The following is a description of a gene set: In addition to its well-characterized role in estrogen-dependent transcription, estrogen (beta-estradiol, also known as E2) also plays a rapid, non-genomic role through interaction with receptors localized at the plasma membrane by virtue of dynamic palmitoylation. Estrogen receptor palmitoylation is a prerequisite for the E2-dependent activation of extra-nuclear signaling both in vitro and in animal models. Non-genomic signaling through the estrogen receptor ESR1 also depends on receptor arginine methylation by PMRT1. <br>E2-evoked extra-nuclear signaling is independent of the transcriptional activity of estrogen receptors and occurs within seconds to minutes following E2 administration to target cells. Extra-nuclear signaling consists of the activation of a plethora of signaling pathways including the RAF/MAP kinase cascade and the PI3K/AKT signaling cascade and governs processes such as apoptosis, cellular proliferation and metastasis. ESR-mediated signaling also cross-talks with receptor tyrosine kinase, NF- kappa beta and GPCR signaling pathways by modulating the post-translational modification of enzymes and other proteins and regulating second messengers. In the nervous system, E2 affects neural functions such as cognition, behaviour, stress responses and reproduction in part by inducing such rapid extra-nuclear responses, while in endothelial cells, non-genomic ESR-dependent signaling also regulates vasodilation through the eNOS pathway. <br>Extra-nuclear signaling additionally cross-talks with nuclear estrogen receptor signaling and is required to control ER protein stability (La Rosa et al, 2012)<br>Recent data have demonstrated that the membrane ESR1 can interact with various endocytic proteins to traffic and signal within the cytoplasm. This receptor intracellular trafficking appears to be dependent on the phyical interaction of ESR1 with specific trans-membrane receptors such as IGR-1R and beta 1-integrin part of: ESR-mediated signaling Reactome Pathway: Extra-nuclear estrogen signaling species: Homo sapiens, and this is the list of marker genes: GNB3, MAPK3, GNAT3, TGFA, KRAS, GNG8, PDPK1, HRAS, MMP3, FOS, CREB1, ZDHHC7, SRC, PRKCZ, GNB2, GNG4, GNG13, STRN, CAV2, UHMK1, GNAI2, BTC, GNG5, EGF, CCND1, GNB5, AKT2, XPO1, ESR2, PIK3R2, HBEGF, GNGT2, MMP2, PTK2, GNG10, CALM1, MMP7, MMP9, AKT1, PIK3R3, GNAI3, SHC1, NOS3, HSPB1, GNB1, GNG11, PIK3CA, BCL2, AREG, CAV1, ELK1, GNG3, FOXO3, MAPK1, GNG2, GNGT1, CDKN1B, PIK3R1, IGF1R, ESR1, S1PR3, GNG12, HSP90AA1, PRMT1, ZDHHC21 (zinc finger DHHC-type palmitoyltransferase 21), NRAS, EREG, EPGN, GNG7, EGFR, SPHK1 (sphingosine kinase 1), AKT3, GNB4, SRF, GNAI1